The following is a description of a gene set: Human Gene Set: HP_AMBIGUOUS_GENITALIA_FEMALE studied in species Homo sapiens Ambiguous genitalia, female Ambiguous genitalia in an individual with XX genetic gender., and this is the list of marker genes: MKS1, CYP19A1, HSD3B2, CYP11B1, TBX15, DHCR24, TNXB, SRY, WT1